The following is a description of a gene set: Mouse Gene Set: REACTOME_METABOLISM_OF_COFACTORS studied in species Mus musculus Metabolism of cofactors, and this is the list of marker genes: Spr, Coq6, Gchfr, Stard7, Pdss2, Hpdl, Coq5, Aco1, Coq4, Akt1, Coq8a, Pdss1, Idh1, Calm2, Coq3, Coq2, Coq8b, Pts, Calm3, Coq7, Coq9, Nos3, Gch1, Hsp90aa1, Calm1